The following is a description of a gene set: species: Homo sapiens Any process that stops, prevents, or reduces the frequency, rate or extent of natural killer cell activation. Human Gene Set: GOBP_NEGATIVE_REGULATION_OF_NATURAL_KILLER_CELL_ACTIVATION, and this is the list of marker genes: FGR, PIBF1, CLEC12A, PGLYRP1, CLNK, RHBDD3, PGLYRP2, PGLYRP3, HLA-E, MICA, HAVCR2